Given this list of marker genes Jak3, Fnip1, Ada, Fcmr, Mir19a, Mir93, Mir363, Nfkbiz, Tnfrsf21, Blm, Noc2l, Bbc3, Wnt5a, Bcl3, Prelid1 (PRELI domain containing 1), Gli3, Ripk1, Cd27, Mir18, Lipa, Tnfrsf4, Cd274, Tsc22d3, Lgals3, Nfkbid, Cd3g, Traf3ip2, Chek2, Foxp1, Bcl10, Bcl2, Il7r, Fadd, Pnp, Mir20b, St3gal1, Rorc, Crkl, Arg2, Siva1, Dffa, Mir19b-1, Mir20a, Slc46a2, Mir92-1, Akt1, Cd74, Ripk3, Pkn1, Irs2, Il21, Mir106b, Fasl, Kifap3, Pdcd7, Prkcq, Ido1, Slc39a10, Il3, Mir17, Lmbr1l, Zc3h8, Hif1a, Bcl2l11, Serpinb9, Pdcd1, Cd24a, Dock8, Aurkb, Il2ra, Il10, Pip, Mir92-2, Bmp4, Kdelr1, Fas, Mir19b-2, Ptcra, Bak1, Lyn, Hsh2d, Adam8, Perp, Mir106a, Mir25, Ccl5, P2rx7, Gpam (NCBI Gene Id 14732), Vhl, Casp7, Bcl11b, Cd44, Ormdl3, Gimap8, Rps6, Dnaja3, Prkd2 (NCBI Gene Id 232912), Tnfsf4, Tgfb2, Il2, Cd47, Mir18b, Casp8, Efna1, Trp53, Mif, Rag1, Bax, Bcl2a1a, Birc7, Siglec1 (sialic acid binding Ig-like lectin 1, sialoadhesin), Pten, Ebf4, Myc, here is a description of the gene set: studied in species Mus musculus Any apoptotic process in a lymphocyte, a leukocyte commonly found in the blood and lymph that has the characteristics of a large nucleus, a neutral staining cytoplasm, and prominent heterochromatin. Mouse Gene Set: GOBP_LYMPHOCYTE_APOPTOTIC_PROCESS